Given this list of marker genes Xrcc1, Parp2, Rnf146, Aifm1, Aplf, Hpf1, here is a description of the gene set: Mouse Gene Set: GOMF_POLY_ADP_D_RIBOSE_BINDING Binding to polymeric ADP-D-ribose, a polymer that is composed of poly-ADP-D-ribose units linked through 1,2-glycosidic bonds at the ribose ring. species: Mus musculus